The following is a description of a gene set: Human Gene Set: GNF2_ITGB2 Neighborhood of ITGB2 integrin, beta 2 (complement component 3 receptor 3 and 4 subunit) in the GNF2 expression compendium species: Homo sapiens Neighborhood of ITGB2, and this is the list of marker genes: MYO1F, RAB27A, TMEM127, RGS2, BIN2, FGR, ITGB2, FMNL1, ITGAX, DPEP2, TCIRG1, APOBR, ELF4, MYD88 (NCBI Gene Id 4615), LST1, RIN3, IL10RA, ARRB2, PSTPIP1, AOAH, PECAM1, EFHD2 (NCBI Gene Id 79453), GMIP, WAS, FBXL5, TUT7, AIF1, TYROBP, HCK (NCBI Gene Id 3055), HSD17B11, GMFG, ICAM3, IRF1, LILRA1, ADA2, FCER1G, MSN (moesin), CMTM6, CASP1, TNFRSF1B, ITGAM (NCBI Gene Id 3684), MCL1, ADGRE5, PLCB2, SH3BGRL3, DOK2, S100A4, SELPLG, THEMIS2, PYCARD, HCLS1, IQGAP1, ACAP2 (ArfGAP with coiled-coil, ankyrin repeat and PH domains 2), OSTF1, ADAM8, PTGER4, RHOG